Given this list of marker genes ZBTB18, TBCK, FH, FGF13, PI4KA, CDC42BPB, CLCN3, MYL9, PIGA, KANSL1, BNC2, here is a description of the gene set: species: Homo sapiens Human Gene Set: HP_FETAL_PYELECTASIS Fetal pyelectasis Mild pyelectasis is defined as a hypoechoic spherical or elliptical space within the renal pelvis that measures at least 5mm and not more than 10 mm. The measurement is taken on a transverse section through the fetal renal pelvis using the maximum anterior-to-posterior measurement.